The following is a description of a gene set: species: Mus musculus Mouse Gene Set: GOCC_OXIDOREDUCTASE_COMPLEX Any protein complex that possesses oxidoreductase activity., and this is the list of marker genes: Bckdha, Dlat, Dlst, Dbt, Ndufb6, Ndufb2, Ndufb3, Cyb5r3, Uqcc3, Sdhb, Pdhx, Cox6a2, mt-Co2, Ndufc2, mt-Nd6, Ndufa11, Nox3, Ndufs6b, Bckdk, Cox6c, Ndufa4l2, Ndufa11b, Ndufa1, Gldc, Wdr93, Cat, Cox6b2, Cox8a, Cox4i1, Dld, Idh3g, Ndufs8, Foxred1, P4ha1, Cox5a, Pdha2, Ndufb4, Ndufa13, Ndufb10, Noxa1, Ndufs1, Hsd17b8, Ndufb5, Ldha, Ndufa7, Mtarc1, Ogdh, Ndufab1, Cox8b, Cox8c, Ndufa12, mt-Nd4, Ncf2, Cox7a2l, Ndufv2, Idh3a, Duox1, P4hb, Ogdhl, Ndufa8, Ndufa4, Nox1, Duox2, mt-Nd1, mt-Nd3, Ldhb, Hadhb, Gmpr, Cox7c, Cyb5b, Acacb, Ndufb11, Ndufb4c, mt-Nd5, Gmpr2, Pdk1, Uqcrc1, Ndufb8, Ndufs6, mt-Co1, Ncf1, Uqcr10, Ndufs2, Uqcrh, Ndufs4, Sdhc, Cox5b, Cox7a1, Noxo1, Idh3b, Ndufs5, Cox7b2, Sdhd, P4ha2, Abhd11, Ndufb9, Cox4i2, Rrm2, Ndufa2, Ndufb4b, Cox6b1, Cox7a2, Cbr4, Ndufb11b, mt-Nd4l, Ndufaf2, Dmac2 (distal membrane arm assembly complex 2), Dhtkd1, Uqcrb, Ndufv1, Pdhb, Gcsh, Uqcrfs1 (ubiquinol-cytochrome c reductase, Rieske iron-sulfur polypeptide 1), Cyc1, Cox6c2, Uqcrq, Ndufc1, Ndufb1, Kat2a, mt-Co3, Ndufb7, Amt, Rrm2b, Ndufs7, Mrps36, Ndufa3, Ndufa6, Uqcrh-ps1 (ubiquinol-cytochrome c reductase hinge protein, pseudogene 1), Ndufa5, Hadha, Ndufa9, Nox4, mt-Cytb, Uqcr11, Ndufs3, Ncf4, Pdk2, Cybb, Ndufv3, mt-Nd2, Rrm1, Bckdhb, Sdha, Cox7b, Pdha1 (pyruvate dehydrogenase E1 alpha 1), Ndufab1-ps, Dmac1, Rac2, Uqcrc2, AA467197, Cyba, Cox6a1, Ndufa10